The following is a description of a gene set: Any process that modulates the frequency, rate or extent of the regulated release of corticotropic hormone from a cell. Mouse Gene Set: GOBP_REGULATION_OF_CORTICOTROPIN_SECRETION studied in species Mus musculus, and this is the list of marker genes: Ecrg4, Lif, Pex5l, Ucn, Apln, Crh, Crhbp, Ghrl, Rab8b